Given this list of marker genes DDX21, WDR77, USP10, ARL4C, GMPPB, NME1, BNC1, NOP56, MRPL20, CORO1C, EBNA1BP2, HSPA4, RCL1, SERP1, SRXN1, TMEM97, ST3GAL4, SRSF2, GREM2, CCL2, ST6GAL1 (ST6 beta-galactoside alpha-2,6-sialyltransferase 1), GNL3, here is a description of the gene set: from publication Mulligan C, Rochford J, Denyer G, Stephens R, Yeo G, Freeman T, Siddle K, O'Rahilly S (PMID 12213819) Human Gene Set: MULLIGAN_NTF3_SIGNALING_VIA_INSR_AND_IGF1R_UP studied in species Mus musculus Insulin and insulin-like growth factor-1 (IGF-1) act through highly homologous receptors that engage similar intracellular signaling pathways, yet these hormones serve largely distinct physiological roles in the control of metabolism and growth, respectively. In an attempt to uncover the molecular mechanisms underlying their divergent functions, we compared insulin receptor (IR) and IGF-1 receptor (IGF-1R) regulation of gene expression by microarray analysis, using 3T3-L1 cells expressing either TrkC/IR or TrkC/IGF-1R chimeric receptors to ensure the highly selective activation of each receptor tyrosine kinase. Following stimulation of the chimeric receptors for 4 h, we detected genes to be differentially regulated, of which 10 were up-regulated to a greater extent by the IGF-1R. These included genes involved in adhesion, transcription, transport, and proliferation. The expression of mRNA encoding heparin-binding epidermal growth factor-like growth factor (HB-EGF), a potent mitogen, was markedly increased by IGF-1R but not IR activation. This effect was dependent on MAPK, but not phosphatidylinositol 3-kinase, and did not require an autocrine loop through the epidermal growth factor receptor. HB-EGF mitogenic activity was detectable in the medium of 3T3-L1 preadipocytes expressing activated IGF-1R but not IR, indicating that the transcriptional response is accompanied by a parallel increase in mature HB-EGF protein. The differential abilities of the IR and IGF-1R tyrosine kinases to stimulate the synthesis and release of a growth factor may provide, at least in part, an explanation for the greater role of the IGF-1R in the control of cellular proliferation. Genes similarly up-regulated in 3T3-L1 cells (fibroblasts able to differentiate to adipocytes) upon stimulation of INSR or IGFR1 by NTF3.